The following is a description of a gene set: studied in species Mus musculus Binding to a neurotrophin TRK receptor. Mouse Gene Set: GOMF_NEUROTROPHIN_TRK_RECEPTOR_BINDING, and this is the list of marker genes: Efna5, Shc1, Frs2, Ngfr, Bdnf, Grb2, Pik3r1, Plcg1